The following is a description of a gene set: part of: Metabolism of proteins Protein synthesis is accomplished through the process of translation of an mRNA sequence into a polypeptide chain. This process can be divided into three distinct stages: initiation, elongation and termination. During the initiation phase, the two subunits of the ribosome are brought together to the translation start site on the mRNA where the polypeptide chain is to begin. Extension of the polypeptide chain occurs when a specific aminoacyl-tRNA, as determined by the template mRNA, binds an elongating ribosome. The protein chain is released from the ribosome when any one of three stop codons in the relevant reading frame on the mRNA is reached. Individual reactions at each one of these stages are catalyzed by a number of initiation, elongation and release factors, respectively.<br>Proteins destined for the endoplasmic reticulum (ER) contain a short sequence of hydrophobic amino acid residues (approximately 20 residues) at their N-termini. Upon protrusion of the signal sequence from the translating ribosome, the signal sequence is bound by the cytosolic signal recognition particle (SRP), translation is temporarily halted, and the SRP:nascent peptide:ribosome complex then docks with a SRP receptor complex on the ER membrane. There the nascent peptide:ribosome complex is transferred from the SRP complex to a translocon complex embedded in the ER membrane and reoriented so that the nascent polypeptide protrudes through a pore in the translocon into the ER lumen. Translation now resumes, the signal peptide is cleaved from the polypeptide by signal peptidase as the signal peptide emerges into the ER, and elongation proceeds with the growing polypeptide oriented into the ER lumen.<br>The 13 proteins encoded by the mitochondrial genome are translated within the mitochondrion by mitochondrial ribosomes (mitoribosomes) at the matrix face of the inner mitochondrial membrane. Mitochondrial translation reflects both the bacterial origin of the organelle and subsequent divergent evolution during symbiosis. Mitoribosomes have shorter rRNAs, mitochondria-specific proteins, and rearranged protein positions. Mitochondrial mRNAs have either no untranslated leaders or very short untranslated leaders of 1-3 nucleotides. Translation begins with N-formylmethionine, as in bacteria, and continues with cycles of aminoacyl-tRNA:TUFM:GTP binding, GTP hydrolysis and dissociation of TUFM:GDP. All 13 proteins encoded by the mitochondrial genome are hydrophobic inner membrane proteins which are inserted cotranslationally into the membrane by an interaction with OXA1L. Translation is terminated when MTRF1L:GTP recognizes a UAA or UAG codon at the A-site of the mitoribosome. The translated polypeptide is released and MRRF and GFM2:GTP act to dissociate the 55S ribosome into 28S and 39S subunits. studied in species Homo sapiens Reactome Pathway: Translation, and this is the list of marker genes: PSMB7, EIF2B3, MRPL28, MRPL55, MRPL51, 28S rRNA, RPL17, PPA2, MRPS18B, FAU, EIF4G1, RPS8, RPS21, MT-ND1, RPL37A, RPS24, MRPL38, MRPL50, MRPL17, RPL3 (NCBI Gene Id 6122), RPS25, MRPS18A, RPL37, PSMC6, AIMP2, EEF2, VCP, PSMB6, RPS10, FARSA, RPL26, MT-TR, EIF4EBP1, RPL26L1, RPL27A, RPL24, AIMP1, TRIP4, MT-CO3, RPS17, EEF1D, RPS15, PSMD2, UBE2D2, MTIF3, EIF4E, MRPL49, RPL4, PSMA1, TUFM, MRPL4, MTRF1L, MRPL47, SSR4, MRPL27, 5.8S rRNA, RPL28, RPS4Y2, PSMB5, RPL15, NARS1, FARSB, EEF1B2, RPS7, CHCHD1, EIF3E, LARS1, MT-TP, RPL36, MT-ND4, SRP9, RPL35, EIF2B5, EIF4H, SEC11A, MRPS27, PSMC1, RPL36AL, RPN1, PSMD13, RPS12, ADRM1, EIF2B1, RPL3L, MRPL32, MRPS5, MRPS24, 7SL RNA (ENSG00000222639), PSMD3, APEH, RPS11, MRPL15, MT-CYB, RPL22, RPL7, NARS2, PSMB2, TARS2, MT-ND3, PSMD8, OXA1L, MRPS11, RPL10A (NCBI Gene Id 4736), RPL23A, EIF3C, MT-ND6, MRPS30, EIF3M, RPL8, SPCS1, MT-TD, RARS1, MT-TC, PSMD1, RPL41, MRPL2, EIF4B, MRPS14, EEF1A1P5, MRPS23 (NCBI Gene Id 64952), NPLOC4, NDUFAB1, ZNF598, RPL13A, RPSA, MRPL39, MIEF1, SRPRB, MRPS25, RPS27L, SPCS2, MT-RNR1, RPL35A, EIF1AX, UBA52, MRPL44, MT-TA, RPL34, RPL29, MT-TS1, MRPL43, EIF2B2, MRPL10, RPS15A, ELOB, UBB, RPS29, MT-TF, MTIF2, MRPL22, RPL11, MRPL9, TRAM1, EEF1E1, MRPS10 (NCBI Gene Id 95834), MRPL13 (NCBI Gene Id 65002), MRPS15, RPL21, RPS27, RPS20, 18S rRNA, ERAL1, RPS23, RPL36A, LARS2, MRPS9, GARS1, MT-TL2, MRPS16, MRPL18, PSMA3, PSMA4, EIF4A1, MARS1, RPS14, RPS6, MT-ATP6, GSPT1, RPS4X, MRPS18C, RPS26, SSR3, RCHY1, EIF5B, MRRF, MT-TG, RPL39L, MRPL35, RPL6, RPS3, SRP68, GADD45GIP1, EPRS1, RPLP2, RPL27, MRPL58, RPL18A, MT-TW, SRP14, NEMF, RPL19, MTRFR, MRPL24, RPL23, HBS1L, PSMD11, PSMC5, UFD1, RPS18, PSMB4, RPL5, PSMC2, MT-ND2, EIF3A, MRPS12, PELO, RPS13, MRPS28, MRPS6, HARS2, EIF3I, MRPL20, SSR1, VARS1 (valyl-tRNA synthetase 1), RPL13, RPS4Y1, RPL10L, QARS1, SEC61B, MARS2, RPS2, HARS1, SEC61A1, KARS1 (lysyl-tRNA synthetase 1), EIF2B4, VARS2 (valyl-tRNA synthetase 2, mitochondrial), MRPL40, RPL38, MT-TT, PSMA2, RPL7A, SRP19, DARS2, MT-TK, WARS2, MRPL41, MRPS22, UBC, RPS5, MRPL33, LTN1, MRPL23, TCF25, MT-ATP8, MT-RNR2, SSR2 (signal sequence receptor subunit 2), MRPL12, DAP3, EEF1A1, MRPL19, RPL10, MRPL3, ASCC3, SRP72, MRPS26, EIF3H, MRPS34, GFM1, MRPL46, SPCS3, RPN2, RPL18, KLHDC10, RBX1, MRPL53, DARS1, PSMD6, FARS2, MRPS31, MT-ND5, PTCD3, RPL30, MTRES1, SEM1, RPS3A, GSPT2, SEC11C, CARS2, ETF1, MT-TN, TARS1, MT-TL1, MT-TQ (NCBI Gene Id 4572), RPL9, MRPS21, PARS2, EIF3K, CUL2, MRPL36, MRPL52, EIF3F, EIF3G (eukaryotic translation initiation factor 3 subunit G), PSMD12, RPLP1, MRPS2, EIF3L, CARS1, WARS1, UBE2D3, MTFMT, RPS19, MRPL37, SRPRA, SEC61A2, EIF2S3, MRPL48, PSMD14, RPS28, EIF2S2, MRPL57, MRPL42, EIF3J, ANKZF1, PSMA5, RPL14, MRPL21, RPL32, KGD4 (alpha-ketoglutarate dehydrogenase subunit 4), MT-TS2, RPL12, PSMC3, RPS27A, TSFM, EEF1G, EIF3D, ABCE1, MT-ND4L (mitochondrially encoded NADH:ubiquinone oxidoreductase core subunit 4L), MALSU1, YARS2, MT-CO1, PSMC4, MTRF1, MT-TE, PABPC1, RPS16, UBE2D1, RPLP0, PPA1, MT-CO2, MRPS35, ASCC2, PSMB1, MRPL11, MRPL1 (mitochondrial ribosomal protein L1), MRPL30, RPL22L1, MT-TY, IARS2, MRPL16, EIF3B, AARS2, RPL31, EIF4A2, RPS9, GFM2, PSMB3, MRPL34, RPL39, MRPS33, MRPL14, 7SL RNA (ENSG00000222619), MT-TV (NCBI Gene Id 4577), TRMT112, MT-TI, MT-TH, SEC61G, EARS2, RARS2, MRPL54, EIF2S1, SARS1, PSMA6 (NCBI Gene Id 87553), MT-TM, EEF1A2, MRPS7, MRPL45, SRP54 (signal recognition particle 54), AARS1, DDOST, 5S rRNA, ELOC, YARS1, PSMA7, HEMK2, EIF5, IARS1, PSMD7 (proteasome 26S subunit, non-ATPase 7), AURKAIP1, SARS2, MRPS17